Given this list of marker genes Cdk5r1, Xbp1, Cd40lg, Ifng, Ciita, Tlr4 (toll-like receptor 4), Jak2, Il4, Tmem106a, Sirt1, Il33, Il10, here is a description of the gene set: Mouse Gene Set: GOBP_POSITIVE_REGULATION_OF_MHC_CLASS_II_BIOSYNTHETIC_PROCESS Any process that activates or increases the frequency, rate or extent of the chemical reactions and pathways resulting in the formation of MHC class II. studied in species Mus musculus